The following is a description of a gene set: from publication Ramirez K, Chandler KJ, Spaulding C, Zandi S, Sigvardsson M, Graves BJ, Kee BL (PMID 22608498) studied in species Homo sapiens Genes down-regulated in common lymphoid progenitors versus granulocyte-monocyte progenitors. Human Gene Set: GSE37301_COMMON_LYMPHOID_PROGENITOR_VS_GRAN_MONO_PROGENITOR_DN Expression profiling of Rag2-deficient Ets1++ and Rag2-deficient Ets1-- mature NK cells and WT bone marrow progenitors, WT T cells, and WT Pro B cells, and this is the list of marker genes: IFITM1, DALRD3, GGA2, TRIM58, SLC16A2, RPL22, RCE1, H2BC9, IFNGR2, TSGA10, SIGLEC1, LGR4, YBX2 (Y-box binding protein 2), PARN, PSIP1, LRRN3, MYOG, FOCAD, PLXNB2, SPON1, TANC2, H4C1, POLR3G, SH3GL2, PLK2, GPC4, CFAP74, ATP10A, DENND5A, OR2C1, SLC17A7 (solute carrier family 17 member 7), CRTAM, GSAP, AQP1, HOXC6, RBM4, RIOX2, CCDC51, TNFRSF11B, LRRK1, LY96, TPK1, TBC1D8B, CYSLTR1, EEF1B2, LINC00588, CES1P1, SEPTIN11, SCUBE2, ADK, NDN, ADSL, SNCG, SYN3, PABPC3, GABRG2, AIRE, BIRC3, PTHLH, SLCO1B3, ICE2, FXYD2, GON4L, SLC25A15, PON2, SLC52A1, CCR7, SENP6 (SUMO specific peptidase 6), OPN3, ART1, ZPR1P1, ZNF334, NMU, ZPBP, ITK, WDR41, SLC25A38, SYF2, OR2F2, PRMT3, EIF3H, BRPF1 (bromodomain and PHD finger containing 1), DSCAM, EVI2B, TNFRSF4, RETREG1, LDHB, KRT23, CEP83, HEXIM1, IL27RA, CYP39A1, SNN, DLG4, NREP, RPL26 (NCBI Gene Id 6154), BEND5, MYO15B, PAX1, EPHB2, ACO1, CXCL13, THAP9, TNPO2, SERPINB1, TRIM14, TUBB7P, DDT, CHST2, SPHK1, ITGA6, ARHGAP15, KRT7, ST13, FEZ2, CEP170, VNN2, PRRC2B, JAM2, SLC39A4, SEZ6L, SMYD3, TFAP4, PLXNB1, WDR11, PARP11, RPS8, LRP5L, OSBPL7, GPR32, CDC40, ARHGAP12, NAT8, ITIH5, HSPA12A, SWAP70, PIKFYVE, PLEC, PTGDR2, PIP, CSNK2A2, GNG13, HMOX1, CLEC10A, TH, PRKCH, C5AR1, CRB1 (crumbs cell polarity complex component 1), ATP5F1A, SGK1, FAM149B1, CDH16, OXSM, EIF3M, PIGP, SERINC5, MYC (MYC proto-oncogene, bHLH transcription factor), FBXO11, CDKN2A-AS1, C8G, DYSF, RS1, RPS23, SUMO1, LINC00652, PCBP3, SETMAR, DDX42, TCF7, PIP5K1A, HLF, GRIA1, RIN2, CACNB4, PSPH, FAM224A, CD48, PDCL, GFRA3, ACVR2A, CCDC22, IL21R, TSC22D3, L1CAM, SLITRK5, RAB13, COL6A2, TSHB, MAPK8IP2, CDX4, KLHL36, RIDA, DNAI1, SIX6, CSF1R, RPS26